The following is a description of a gene set: Genes down-regulated in comparison of dendritic cells (DC) versus DCs exposed to M.tuberculosis. from publication Chaussabel D, Semnani RT, McDowell MA, Sacks D, Sher A, Nutman TB (PMID 12663451) Human Gene Set: GSE360_CTRL_VS_M_TUBERCULOSIS_DC_DN species: Homo sapiens Monocyte-derived dendritic cells (DC) and macrophages (MΦ) generated in vitro from the same individual blood donors were exposed to five different pathogens, and gene expression profiles were assessed by microarray analysis. Responses to Mycobacterium tuberculosis and to phylogenetically distinct protozoan (Leishmania major, L. donovani, Toxoplasma gondii) and helminth (Brugia malayi) parasites were examined, each of which produces chronic infections in humans yet vary considerably in the nature of the immune responses they trigger., and this is the list of marker genes: TUBB2A, NRP2, MT1H, CCL3, VEGFA, AGRN, IER3, TNFSF10, AASS, MT3, TNIP1, AURKB, RBMS1, RRH, LCP2, SOX9, CD163, CCNA1, CUL1, SMURF2, CCL8, MMP12, EPOR, RELB (RELB proto-oncogene, NF-kB subunit), IFRD1, MUC4, LYN, SQSTM1, MARCO, CKAP4, KCNJ10, CEACAM5, CD83, FGFR2, PFKFB3, MAP2K3, SCARB2, OAS2, SEC61B, TUBB3, IRF9, BST2, FICD, CCL4, STK4, ERC2-IT1, LBP, PLAAT4, SLC2A5, DLEC1, H2BC21, WARS1, TNIK, TSFM, TRAF1 (NCBI Gene Id 7185), GPD2, TXN, ELL2, RSC1A1, AMHR2, BRCA2, OBSL1, HSF4, OLR1, NR4A3, CD44, IFNG, ACSL1, F13B (NCBI Gene Id 2165), PLXNC1, MT2A, S100A11, NCALD, ADRB2, SNTB2, RUNX3, SPINK4, TRIB1, NDRG1, LITAF (lipopolysaccharide induced TNF factor), WTAP, WSCD2, AK4, STAT3, S100A9, IFI6, PPP1R3C, RNF19B, RARRES1, FCGR2A, SERPINH1, ATP6V1E1, GBP1, NFKBIA, IL1RN, GSR, IFIT2, SSB (small RNA binding exonuclease protection factor La), STAT2, MANF, MMP7, H2AC16, S100A8, CDH1 (cadherin 1), PDPN, PSMA5, LHFPL2, TAPBP, L3MBTL1, COL5A2, DNAJB1, HSPA8, HESX1, MMP9, CSF2RB, GLUL, FCGR3B, ARL4A, MT1B, PCDHGA8, CASP1, LRP8, G0S2, PTK2B, TGM3 (transglutaminase 3), MAGEA5P, ALDH1A2, KARS1, MSC, GADD45A, SRSF3, SRGN, COBL, IL2RG, MT1G, ADA, CCR7, GNRH2, EFHD1, CYB5A, IL10, IFITM2, CPNE6, TRAFD1, ATN1, WIPI1, CD38, SRSF2, RASGRP1, CRLF3, GH1, TOM1, ATG4A (NCBI Gene Id 115201), RGS1, CHST7, KRT86, CYRIA, GBP2, MUC6, C3AR1, FSCN1, ANKRD12, ATF5, WBP2, GNA12, GREM1, VAMP5, DUSP5, ATP2A2, SBNO2, PARP2, LILRB2 (NCBI Gene Id 10288), TNFAIP2, SKI, EHBP1, TRIP4, PPARD, LDHA, VCAN, MFAP3, IFI44, GP1BA, CD80 (CD80 molecule), ZNF785 (zinc finger protein 785), LYPD3, SIK3, STX11, IQSEC2, GBX2, ICAM1, ACP2, OMD, SYMPK, DYNLL1, KYNU, KEL, TYMP, MCCC2, SLPI, TUBB (NCBI Gene Id 95295)